Given this list of marker genes SH3BP2, FOCAD, HMGA1, TXNDC11, SNRPF, CRABP2, SSR1, PRSS16 (serine protease 16), MYADM, ITGB1BP2, NKPD1, BSPRY, IL10, GZMA (NCBI Gene Id 3001), UBE2T, SLC2A4, PDIA5, IQGAP2, IL13, SV2C, ABHD17C, SELP, SLC16A1, IL12RB2, TET1, PELI1, EPAS1, NKX2-8, CCNC, HELQ, C1QL1, CYP2R1, TMEM35A, AGPAT3, GCLC, EEF1G, PTGIR (prostaglandin I2 receptor), PLAC8, PPP1CC, DSCC1, CHORDC1, ADORA2B, SLC39A4, TUBA3C, ETS1, TG, SUB1, CEP85, GNG12, MYEF2, CHID1, CCR4, TERF1, TSPAN4 (tetraspanin 4), TSEN15, CORO2A, TCEANC, EZR, TOMM20, HIVEP3 (NCBI Gene Id 86368), BCL2, SNRPB2, APOBEC3B, FASLG, TOR2A, GFI1, ASNS, CDYL, RPL9 (NCBI Gene Id 6133), DENND3, SOCS2, USP14, ENKD1, CMPK2, ARHGAP33, PROS1, PSMA3, LRRC42, STRN3, ACBD7, TMEM170B (NCBI Gene Id 100113407), PMP22, HNRNPF, MYCN, ASB2, GPT2, SLC16A6, CBX1, NEB, GBP7, GBP2, TUBD1, RIOK1, MCM2, FCMR, CHCHD10, SLC3A2, SHROOM2, HEMGN, FLJ13224, ENTPD1 (NCBI Gene Id 953), SRP68, SLC16A10, MGAT1, IL2RA, RRAS2, SLIRP, KCNJ1, SOCS1, ARL6IP6, DRC12, GFRA2, L2HGDH, ELMO2, METTL25, TBKBP1 (NCBI Gene Id 9755), ABHD16A, CNR2, TACC2, ACOT4, MIER1, NXPH4, FZD10, IL12RB1, IRX1, NEDD4, GTPBP3, DOCK10, CEBPB, CENPU, IMPDH1, CHD7, CCDC141, ATAD5, RBPJ, CLTC, ITIH5, LYST, GZMB, INTS14, IL2RB, C9orf152, AKR1C3, ARMCX3, MANF, BLTP1, ZNF664, ALCAM, SDF2L1, TOMM70, ADAM10, GALNS, NAGS (NCBI Gene Id 162417), PICALM, ARHGEF16, KIF3A (kinesin family member 3A), COX6A2, HOXC13, IL7R, ANP32B, PELI2, SSR2, KCNK5, PLXND1 (plexin D1), XBP1 (NCBI Gene Id 7494), PRDM1, RUNX3, PAQR4, TRAPPC13, HPGD, LAT, GARIN3, SEPTIN3 (NCBI Gene Id 55964), PSPH, MAP2K4 (mitogen-activated protein kinase kinase 4), G2E3 (G2/M-phase specific E3 ubiquitin protein ligase), DCAF1, TTLL12, TEX2, ARMC2, MLPH, GPM6B, MRPS31, PRC1, TP53I11, IZUMO1R, ZBTB16, HNRNPA2B1, PCDH11X, SOAT2, F2R, IL4, HSP90B1, LPCAT4, DGKK, GEMIN8, VCAN, CENPO, TREML2, KLRK1, here is a description of the gene set: studied in species Homo sapiens Human Gene Set: GSE14350_IL2RB_KO_VS_WT_TEFF_DN Genes down-regulated in comparison of effector T cells from IL2RB defficient mice versus effector T cells from wild type animals. Interleukin-2 receptor (IL-2R) signaling is essential for T regulatory (Treg) cell development and homeostasis. Here we show that expression of IL-2Rbeta chains that lack tyrosine residues important for the association of the adaptor Shc and the transcription factor STAT5 in IL-2Rbeta-deficient mice resulted in production of a normal proportion of natural Treg cells that suppressed severe autoimmunity related with deficiency in IL-2 or IL-2R. These mutant IL-2Rbeta chains supported suboptimal and transient STAT5 activation that upregulate the transcription factor Foxp3 to normal amounts in natural, but not induced, Treg cells. Using cells T cell obtained from normal C57BL/6 mice and mice harboring Treg cells with impaired IL-2R signaling, gene expression profiling revealed many targets in peripheral natural Treg cells that were IL-2-dependent and a substantial overlap between the Treg cell IL-2-dependent gene program and the Treg cell transcriptional signature. Collectively, these findings demonstrate that a critical, and perhaps minor, subset of IL-2-dependent targets in Treg cells is indexed to a low IL-2R signaling threshold and that a substantial proportion of the Treg cell gene program is regulated by IL-2. CD4 T effector cells also showed many IL-2R-dependent gene and these also overlapped in a distintive manner with the IL-2-dependent genes of Treg cells and the Treg gene signature. from publication Yu A, Zhu L, Altman NH, Malek TR (PMID 19185518)